Given this list of marker genes Vav2, Prkd3, Gabrb3, Map4, Kcnip1, Zfp422, Enpp6, Micall2, Tmem229a, Fzd7, Unk, Cited2 (Cbp/p300-interacting transactivator, with Glu/Asp-rich carboxy-terminal domain, 2, NCBI Gene Id 17684), Fgfr2, Zbtb24, Ppargc1a, Proser2, Bysl, Sp3, Pdhx, Samd4, Lrrc14b, Stom, Galnt3, Mrgpre, Epas1, Cfap90, Ndufa4, Antxr2, Ifna12, Efhc1, Cdh20, Zfp516, Mical3, Vti1a, Serpina5 (serine (or cysteine) peptidase inhibitor, clade A, member 5), Gid8, Mef2a, Lrrc19, Adamts6, Kcnip4, Mrps17, Tab3, Gpatch8, Dmxl2, Scn1a, Six4, D5Ertd579e, Camsap2, Tcl1b4, Baz2b, Hmgcr, Nr1d2, Cntnap2, Slc16a1, Golga5, Tent4b, Ctns, Sox2, Col15a1, Rras2, Eif3j1, Helz2, Ubox5, Grik3, Serpina3i, Pgbd1, Zhx1, Lmnb1, Lrrc58, Adgrb3, Bmper, Dsg1a, Pccb, Mixl1, Mapk10, Hif1a, Mto1, Yod1, Pcf11, Eif3j2, Rhbdd1, Prob1, Phykpl, Ddost, Sned1, Kif13a, Armc8, Zc3h12c, Orai3, Nr5a2, Wwp1, Apobec4, Afap1l1, Gabra1, Camk4, Rnf14, Nlk (nemo like kinase), Mycbp, Inpp4a, Irf2bp2, Chrdl1, Srsf3, Pmaip1, Btg1, Mblac2, Epn2, Ppfibp1, Syt2, Gm20604, Shc4, Tmem198b, Nrip3, Fbxo32, Arcn1, Cdk6, Papola, Sos2, Rab27b, Csmd2, Nopchap1, Dnajb4, Tnfaip1, 1700013H16Rik, Emilin2 (elastin microfibril interfacer 2), Dph2, Orc5, here is a description of the gene set: Genes predicted to be targets of miRBase v22 microRNA mmu_miR_7089_3p in miRDB v6.0 with MirTarget v4 prediction scores > 80 (high confidence targets). from publication Chen Y, Wang X (PMID 31504780) species: Mus musculus Mouse Gene Set: MIR_7089_3P